Given this list of marker genes MOXD2P, NLRP11, PAM, MOXD1, DBH, here is a description of the gene set: Human Gene Set: GOMF_OXIDOREDUCTASE_ACTIVITY_ACTING_ON_PAIRED_DONORS_WITH_INCORPORATION_OR_REDUCTION_OF_MOLECULAR_OXYGEN_REDUCED_ASCORBATE_AS_ONE_DONOR_AND_INCORPORATION_OF_ONE_ATOM_OF_OXYGEN Catalysis of an oxidation-reduction (redox) reaction in which hydrogen or electrons are transferred from reduced ascorbate and one other donor, and one atom of oxygen is incorporated into one donor. species: Homo sapiens